Given this list of marker genes CTSH, CFAP69, SLC24A4, MMP14, CNGB1, here is a description of the gene set: species: Homo sapiens Any process that results in a change in state or activity of a cell or an organism (in terms of movement, secretion, enzyme production, gene expression, etc.) as a result of an odorant stimulus. An odorant is any substance capable of stimulating the sense of smell. Human Gene Set: GOBP_RESPONSE_TO_ODORANT